The following is a description of a gene set: from publication Sarkar S, Kalia V, Haining WN, Konieczny BT, Subramaniam S, Ahmed R (PMID 18316415) studied in species Homo sapiens Using killer cell lectin-like receptor G1 as a marker to distinguish terminal effector cells from memory precursors, we found that despite their diverse cell fates both subsets possessed remarkably similar gene expression profiles and functioned as equally potent killer cells. However, only the memory precursors were capable of making IL-2 thus defining a novel effector cell that was cytotoxic, expressed granzyme B, and produced inflammatory cytokines in addition to IL-2. This effector population then differentiated into long-lived protective memory T cells capable of self-renewal and rapid re-call responses. Mechanistic studies showed that cells that continued to receive antigenic stimulation during the later stages of infection were more likely to become terminal effectors. Importantly, curtailing antigenic stimulation towards the tail-end of the acute infection enhanced the generation of memory cells. These studies support the decreasing potential model of memory differentiation and show that the duration of antigenic stimulation is a critical regulator of memory formation Human Gene Set: GSE10239_KLRG1INT_VS_KLRG1HIGH_EFF_CD8_TCELL_UP Genes up-regulated in comparison of effector CD8 T cells KRLG1 Int vs those with KRLG1 Hi., and this is the list of marker genes: ACOT7, NEK6, PSMG3, MTNAP1, PECR, ANKRD37, DUOX1, ALKBH6, LDHB, FDPS, TOMM20, LSM2, TPD52L2, NME1, DBH, DLX3, PABPC4, FAM162A, HMGXB3, KRT33A, BUD23, SLC25A19, EIF2B2, ZNF428, RABEPK (Rab9 effector protein with kelch motifs), LOX, BATF, MYLK4, RPS19BP1, SPZ1, COL9A2, SNAP47, NAP1L2, SUPT4H1, ETV4, CDKN2A, UBE2QL1 (NCBI Gene Id 134111), TMEM216, POLR2C, EIF4A3, HACD1, RAD1, WNK4, CCN4, SPX, HSPBP1, EIF3D, MRPS7, DHX30, FTMT, GINS2, CACNG3, KCNK10, GLDC, UBXN11, EMG1, MRPL11, BRS3, FURIN, DHRS13, PIN1, CHCHD5, C1orf216, RCCD1, SLC7A1, SHMT2, OAS1, VAC14 (VAC14 component of PIKFYVE complex), OVCA2, C19orf48P, EXOG, ADCK1, TRIM28, MRPS30, NHP2, KLHDC9, POLR2D, FSD2, TPI1, POLDIP2, P3H1 (prolyl 3-hydroxylase 1), ELAC2, SENP3, VDAC1, RAE1, HDAC10, APLN, GGA2, HVCN1, NDN, ESRP1, NR2C2AP, RPRML, DRG2, TRMT1, SLC6A13, NUDT19, MRPL17, PIM2, SLC25A26, EIF2B5, MRPS35, DDX39A, C1orf174, RIOX1, GSTA5, RABL3, ADI1, DTD1, IL34, ATP4A, DCTPP1, GPX1, RPL36, CUEDC2, ACAA1, PRDX3, DDX51, TXNL4A, PFKL, NDUFAF6 (NCBI Gene Id 137682), PSCA, ACSF3, STOML2, GNAO1, ALG9, JAGN1, PDCD5, PGP, GTF2H3, LAYN (layilin), PDSS2, ATIC, HS6ST1, CYB5B, DDX47, SSH3, PPM1F, RBM15B, TFPT, LRP3, TXNDC2, LINGO2, JOSD2, SPRYD4, FABP5, FAM216A, ARX, DNPH1, NOP9, SMIM3, TIMM13, NME8, CFAP221, HOOK2, TMEM69, YBX3, TMEM132E, NAT8L, GABRA6, MRPL22 (mitochondrial ribosomal protein L22), GJB2 (gap junction protein beta 2), CYP51A1, SMG5, TYSND1, ITIH1, STAT5A, ELP3, SLC7A6, WNT4, MED18, ADCK5, PRR3, SLC7A5, CXADR, FAM43B, SNHG6 (small nucleolar RNA host gene 6), KLHDC3, MRPL44, CDH26, COL10A1, SURF6, WDR46, SIVA1, ILF2, RBFA (ribosome binding factor A), CHCHD1, SUSD3, SLC25A33, KARS1, SLC35F2, ALDOA, AARSD1, SIAH2, ALG5, TEAD3, GCN1, PCK1, ZCCHC4, NDUFAF2